Given this list of marker genes CD22, VWF, FCMR, FCGRT, FCER1A, FCGR3B, FCGR2C, FCAR, FCGR1BP, FCGR2B, MS4A1, AMBP, FCGR1A, FCGR3A, JCHAIN, UMOD, PIP, HRG, FCER1G, FCER2, CD4, MS4A2, GRIA1, PIGR, LGALS3, LILRA2, FCGR2A, here is a description of the gene set: species: Homo sapiens Human Gene Set: GOMF_IMMUNOGLOBULIN_BINDING Binding to an immunoglobulin.